Given this list of marker genes CDC20, APC2, ANAPC11, CDC23, ANAPC4, CDC26 (cell division cycle 26), CDH1, ANAPC5, CDC27, ANAPC1, ANAPC10, CDC16, ANAPC7, here is a description of the gene set: Human Gene Set: WAESCH_ANAPHASE_PROMOTING_COMPLEX Subunits of the anaphase promoting complex (APC). Genomic instability can be found in most cancer cells. Cell proliferation is under tight control to ensure accurate DNA replication and chromosome segregation. Cyclin-dependent kinases (Cdks) and their activating subunits, the cyclins, are the driving forces of the cell division cycle. Regulation of cyclin oscillation by ubiquitin-dependent proteolysis thereby has a central role in cell cycle regulation. The anaphase-promoting complex (APC) is a specific ubiquitin ligase and is essential for chromosome segregation, exit from mitosis and a stable subsequent G1 phase allowing cell differentiation or accurate DNA replication in the following S phase. The APC is activated by the regulatory subunits Cdc20 (APC(Cdc20)) and Cdh1 (APC(Cdh1)) to target securin, mitotic cyclins and other cell cycle regulatory proteins for proteasomal degradation. This review is focused on the role of APC-dependent proteolysis in cell cycle regulation and how its deregulation may lead to genomic instability of cancer cells. from publication Wäsch R, Engelbert D (PMID 15637585) studied in species Mus musculus